Given this list of marker genes HSPA9, YWHAQ, USP9X, DYNLL1, LCA5, HSPA5, DYNLL2, RANBP9, YWHAB, HSPA1L, ELOA, C1QBP, HSPA1A, SET, CSNK2A2, CSNK2B, NAP1L1, YWHAE, CSNK2A1, HSPA1B, HSPA8, NPM1, YWHAG, YWHAZ, YWHAH, NCL, here is a description of the gene set: Proteins shown to interact with LCA5 in vivo. Human Gene Set: DEN_INTERACT_WITH_LCA5 Leber congenital amaurosis (LCA) causes blindness or severe visual impairment at or within a few months of birth. Here we show, using homozygosity mapping, that the LCA5 gene on chromosome 6q14, which encodes the previously unknown ciliary protein lebercilin, is associated with this disease. We detected homozygous nonsense and frameshift mutations in LCA5 in five families affected with LCA. In a sixth family, the LCA5 transcript was completely absent. LCA5 is expressed widely throughout development, although the phenotype in affected individuals is limited to the eye. Lebercilin localizes to the connecting cilia of photoreceptors and to the microtubules, centrioles and primary cilia of cultured mammalian cells. Using tandem affinity purification, we identified 24 proteins that link lebercilin to centrosomal and ciliary functions. Members of this interactome represent candidate genes for LCA and other ciliopathies. Our findings emphasize the emerging role of disrupted ciliary processes in the molecular pathogenesis of LCA. from publication den Hollander AI, Koenekoop RK, Mohamed MD, Arts HH, Boldt K, Towns KV, Sedmak T, Beer M, Nagel-Wolfrum K, McKibbin M, Dharmaraj S, Lopez I, Ivings L, Williams GA, Springell K, Woods CG, Jafri H, Rashid Y, Strom TM, van der Zwaag B, Gosens I, Kersten FF, van Wijk E, Veltman JA, Zonneveld MN, van Beersum SE, Maumenee IH, Wolfrum U, Cheetham ME, Ueffing M, Cremers FP, Inglehearn CF, Roepman R (PMID 17546029) studied in species Homo sapiens